Given this list of marker genes UBA52, XIAP, WWP2, AKT2, OTUD3, PSMC6, PSMB5, TRIM27, CSNK2A1, PTEN, PSMB3, FRK, PSMA4, PSMC5, PREX2, RNF146, PSMA1, AKT1, PSMB2, TNKS2, PSMC4, PSMC1, NEDD4, PSMD1, PSMD13, TNKS, UBC, CSNK2A2, STUB1, PSMA7, PSMD12, PSMB1, SEM1, PSMD7, PSMD11, AKT3, PSMB6, USP13, PSMD6, PSMA6, PSMC3, PSMD8, RPS27A, PSMC2, ADRM1, PSMB7, PSMD3, MKRN1, PSMA3, PSMB4, PSMD14, PSMA2, PSMD2, UBB, CSNK2B, PSMA5, here is a description of the gene set: PTEN protein stability is regulated by ubiquitin ligases, such as NEDD4, WWP2, STUB1 (CHIP), XIAP, MKRN1 and RNF146, which polyubiquitinate PTEN in response to different stimuli and thus target it for proteasome-mediated degradation. Several ubiquitin proteases, such as USP13 and OTUD3, can remove polyubiquitin chains from PTEN and rescue it from degradation. TRIM27 (RFP) is an E3 ubiquitin ligase that polyubiquitinates PTEN on multiple lysines in the C2 domain of PTEN using K27 linkage between ubiquitin molecules. TRIM27 mediated ubiquitination inhibits PTEN lipid phosphatase activity, but does not affect PTEN protein localization or stability.<br>PTEN phosphorylation by the tyrosine kinase FRK (RAK) inhibits NEDD4 mediated polyubiquitination and subsequent degradation of PTEN, thus increasing PTEN half life. FRK mediated phosphorylation also increases PTEN enzymatic activity. Casein kinase 2 (CK2) mediated phosphorylation of the C-terminus of PTEN on multiple serine and threonine residues increases PTEN protein stability but results in ~30% reduction in PTEN lipid phosphatase activity.<br>PREX2, a RAC1 guanine nucleotide exchange factor (GEF) can binds to PTEN and inhibit its catalytic activity. species: Homo sapiens Reactome Pathway: Regulation of PTEN stability and activity part of: PTEN Regulation